The following is a description of a gene set: from publication Fan X, Dong J, Zhong S, Wei Y, Wu Q, Yan L, Yong J, Sun L, Wang X, Zhao Y, Wang W, Yan J, Wang X, Qiao J, Tang F (PMID 29867213) studied in species Homo sapiens Human Gene Set: FAN_EMBRYONIC_CTX_BIG_GROUPS_BRAIN_IMMUNE, and this is the list of marker genes: UCP2, RCSD1, PLAAT4, ITGB2, LIMD2, CNN2, XAF1, ARHGAP15, IFITM1, PSME2, DENND2D, ICAM3, TAGLN2, CLIC1, CCND3, MYH9, JUNB, MBNL1, BTN3A2, ZFP36L2, SEPTIN1, TXNIP, MSN, CARD16, TMC8, DUSP1, CD37, IQGAP1, KLF2, ADGRE5, FCER1G, CRIP1, ADD3, DNAJB1, SERF2, MYL12A (myosin light chain 12A), LTB, ELF1, TAGAP, FYB1, LY6E, S100A6, TSC22D3, IFITM3, HLA-B, GPSM3, IL32, IRF1, RAP1B, CYTIP, PTPRCAP, ARHGDIB, TBC1D10C, ARPC1B, CLEC2D, HCLS1, CD69, PSME1, S100A11, ANXA1, DUSP2, CSK, UTRN, ETS1, RPL28, CD3E, HLA-DRB1, CIB1, ARHGAP45, SYTL1, EEF1D, CORO1A, CLEC2B, LCK (LCK proto-oncogene, Src family tyrosine kinase), GZMA, LY9, ARHGAP9 (Rho GTPase activating protein 9), PSMB9, PFN1, IL2RG, ARHGEF1, ISG15, SP100, GIMAP4, HLA-DRA, ITGAL, GADD45B, FCMR (Fc mu receptor), ISG20, PTPN6, PTPRC, ARPC2, SRGN, BIN2, GMFG, CD44, SP110, FOS, RPL13A, FXYD5, CD96, S100A4, SELL, LRRFIP1 (NCBI Gene Id 9208), STK10, RHOH, RAC2, LSP1, STK17B, CD48 (CD48 molecule), SH2D1A, LITAF, PRR13, RNF213, NEAT1, HLA-E (NCBI Gene Id 3133), FERMT3, IL16, PSMB8, RIPOR2, S100A10, IFITM2, CD52, HLA-C, PLAC8, HLA-F, ACAP1, SKAP1, B2M, VAMP8 (vesicle associated membrane protein 8), AKNA, EMP3, HCST, CD74, PIP4K2A, ABI3, PVRIG, LCP1, SH3BGRL3, GIMAP7, CD7 (CD7 molecule), HLA-A, ZFP36, ANXA11, HLA-H, EVI2B, TAPBP, DOK2